The following is a description of a gene set: Mouse Gene Set: GOBP_INTRINSIC_APOPTOTIC_SIGNALING_PATHWAY_IN_RESPONSE_TO_DNA_DAMAGE species: Mus musculus The series of molecular signals in which an intracellular signal is conveyed to trigger the apoptotic death of a cell. The pathway is induced by the detection of DNA damage, and ends when the execution phase of apoptosis is triggered., and this is the list of marker genes: Mael, Tmem109, Polb, Bcl2l12, Ifi204, Mif (NCBI Gene Id 17319), Ddit4, Cdkn1a, Ercc6, Sod2, Fnip2, Tnfrsf1a, Bcl2l1, Bak1, Bad, Cd74, Atm, Fbh1 (F-box DNA helicase 1), Bcl2l11, Crip1, Brca1, Chek2, Topors, Tnf, Casp2, Bcl2a1b, Bag6, Tmem161a, Brca2, Cd44, Ier3, Mlh1, Bax, Aen, Pmaip1, Ell3, Usp28, Cdkn2d, Mcl1, Atad5, Msh2, Ackr3, Epha2, Bcl2a1c, Hipk2, Nupr1, Knl1, Bid, Hipk1, Bcl2l2, Pml, Moap1, Trp73, Plscr1, Nacc2, Triap1, Uri1, Trim32, Prkdc, Ccar2, Htra2, Bbc3, Mbd4, Tpt1, Casp9, Bcl3, Snai1, Clu, Ikbke, Skil, Usp47, Muc1, Cxcl12 (NCBI Gene Id 20315), Marchf7, Ppp2r5c, Phlda3, Pycard, Hic1, E2f1, Sfn, Dyrk2, Pik3r1, Ddias (DNA damage-induced apoptosis suppressor), Trp53, Shisa5, Sirt1, Snw1, Pnp, Bcl2 (B cell leukemia/lymphoma 2), Tnfrsf1b, Steap3, Bcl2a1a, Bok, Msh6, Hmox1, Rad9a, Bcl2l10 (Bcl2-like 10), Ei24, Kdm1a, Pias4, Ep300, Rpl26, Xpa, Rps3, Trp63, Cdip1, Nfatc4, Mtch2, Snai2, Hnrnpk, Zfp385a, Rps27l, Myc, Uaca, Bcl2a1d